The following is a description of a gene set: Reactome Pathway: Defective Base Excision Repair Associated with NEIL1 NEIL1 is an enzyme with dual DNA glycosylase and beta/delta lyase activity involved in base excision repair pathway (BER), the primary repair pathway for oxidative DNA damage. NEIL1 can detect and remove DNA damage resulting from oxidation of adenine, guanine and thymine, in the form of 4,6-diamino-5-formamidopyrimidine (FapyA), 2,6-diamino-4-hydroxy-5-formamidopyrimidine (FapyG), and thymine glycol (Tg), respectively. NEIL1 can also detect and remove dihydrouracil (DHU), which results from deamination of cytosine. Several low frequency NEIL1 polymorphisms, present in about 1% of general population in the United States have been reported. Different polymorphisms have different effects on NEIL1 function, and it was suggested that NEIL1 polymorphisms and NEIL1 deficiency or haploinsuficiency may be involved in predisposition to cancer and in metabolic syndrome. One polymorphism, NEIL1 G83D, is associated with primary sclerosing cholangitis and cholangiocarcinoma. NEIL1 G83D variant exhibits impaired DNA glycosylase activity towards different damaged DNA bases and induces genomic instability.<br>NEIL1 E28del, an in frame deletion variant of NEIL1 reported in gastric (stomach) cancer, where glutamate at position 28 is deleted, does not cleave Tg from damaged DNA.<br>NEIL1 Q282TER, a NEIL1 variant which lacks the putative nuclear localization signal (NLS), localizes to the cytosol and is therefore not able to access damaged DNA substrates, but its involvement in cancer is uncertain.<br>Reduced expression of NEIL1 and NEIL2 genes, accompanied with increased NEIL3 gene expression was detected in various cancers. NEIL1 gene silencing by promoter hypermethylation may be one of the underlying mechanisms for reduced NEIL1 expression in cancer.<br>Infection with the Hepatitis C virus (HCV) leads to decreased NEIL1 expression in liver cells, through an unknown mechanism.<br>Mice that are double knockout for Neil1 and Nthl1 genes accumulate DNA damage in the form of FapyA and FapyG and are more prone to development of lung adenocarcinoma than single Neil1 or Nthl1 gene knockouts. Another study reported that Neil1 knockout mice did not show a predisposition to tumour formation, and neither did double knockouts of Neil1 and Neil2, nor triple knockouts of Neil1, Neil2 and Neil3. Neil1 knockout mice are obese, consistent with the metabolic syndrome, but double knockouts of Neil1 and Neil2 do not display obesity.<br> studied in species Homo sapiens part of: Diseases of Base Excision Repair, and this is the list of marker genes: NEIL1